Given this list of marker genes Sgcb, Efemp2, Tbx3, Pbrm1, Notch4, Prdm6, Mecp2, Nfatc1, Itga8, Six1, Fgf9, Foxf1, Eng, Kit, Ntf3, C3, Mef2c, Fgfr2, Shh (NCBI Gene Id 20423), Ednra, Acvr1, Mrtfb, Pias1, Zeb1, Tmsb4x, Ctnnb1, Ramp2, Notch2 (notch 2), Tshz3 (NCBI Gene Id 338507), Sox9, Nfatc4, Sod2, Pdgfrb, Mir145a (NCBI Gene Id 387163), Vegfa, Cfd, Wnt7b, Smarcd3, Pdgfb, Mir143, Tbx2, Qki, Smad6, Olfm2, Smarca4, Notch1, Rcan1, Hey1, Smarca2 (NCBI Gene Id 67155), Hes1, Fgf10, Mesp1, Gata6, Agt, Med28, Hey2, Bmp4, Nfatc3, Pitx2, Foxo4, Ankrd17, Ereg, Comp, Rbpms2, Cth, Epc1, Vangl2, Wnt4, Adm, Mrtfa, Prok2, Pdcd4, Tgfb1, Cfh, Aplnr, Nfatc2, Sirt1, Tbx18, Srf, Npnt, Dnmt1, Myocd, Ednrb, Tmem204, Gper1, here is a description of the gene set: species: Mus musculus The process in which a relatively unspecialized cell acquires specialized features of a smooth muscle cell; smooth muscle lacks transverse striations in its constituent fibers and are almost always involuntary. Mouse Gene Set: GOBP_SMOOTH_MUSCLE_CELL_DIFFERENTIATION